Given this list of marker genes NT5C1A, DPYS, NT5C2, UPP2, TYMP, UPP1, XDH, PNP, ADA, GDA, NT5C, NT5M, DPYD, UPB1, DNPH1, here is a description of the gene set: studied in species Homo sapiens Human Gene Set: GOBP_DEOXYRIBONUCLEOSIDE_MONOPHOSPHATE_CATABOLIC_PROCESS The chemical reactions and pathways resulting in the breakdown of a deoxyribonucleoside monophosphate, a compound consisting of a nucleobase linked to a deoxyribose sugar esterified with phosphate on the sugar.